Given this list of marker genes Mocs3, Trmu, Urm1, Ctu2, Ctu1 (cytosolic thiouridylase subunit 1), here is a description of the gene set: studied in species Mus musculus The addition a sulfur atom to a nucleotide in a tRNA molecule. Mouse Gene Set: GOBP_TRNA_THIO_MODIFICATION